The following is a description of a gene set: Mouse Gene Set: REACTOME_PLASMA_LIPOPROTEIN_ASSEMBLY Plasma lipoprotein assembly species: Mus musculus, and this is the list of marker genes: Apoa4, Apoc4, Apoc2l, Apoa1, Apoc2, Mttp, Apoa2, Bmp1, Sar1b, Prkaca, Abca1, Apob, A2m, P4hb, Apoe, Prkacb, Zdhhc8, Apoc1